Given this list of marker genes RUNX2, HOXD13, SLC39A13, SLC26A2, SELENOI, here is a description of the gene set: Human Gene Set: HP_MODERATELY_SHORT_STATURE Moderately short stature A moderate degree of short stature, more than -3 SD but not more than -4 SD from mean corrected for age and sex. species: Homo sapiens